The following is a description of a gene set: species: Homo sapiens Human Gene Set: REACTOME_CYCLIN_A_CDK2_ASSOCIATED_EVENTS_AT_S_PHASE_ENTRY Cyclin A:Cdk2-associated events at S phase entry, and this is the list of marker genes: ADRM1, AKT3, PSMD11, CDKN1A, PSMD7, MAX, CDC25A, WEE1, CDK7, PSMB2, SKP1, LIN54, SEM1, TFDP1, PSMB1, CUL1, E2F4, UBA52, CCNE1, UBC, PSMB7, CCNA2, CCNE2, PSMC2, CDKN1B, MYC, PSMC4, PSMC1, LIN52, PSMB6 (proteasome 20S subunit beta 6), CDK2, E2F5, CABLES1, PSMB4, TFDP2, PSMD8, PSMB5, PSMA6, PTK6, PSMD6, PSMB3, LIN37, CKS1B, RBL2, FZR1, CCND1, LIN9, PSMD14, PSMA7, UBB (NCBI Gene Id 91253), PSMC5, PSMD3 (proteasome 26S subunit, non-ATPase 3), PSMC6, CDK4, PSMA1, CDC25B, CCNH, PSMA3, AKT2, CCNA1, PSMA2, RB1, RBBP4, AKT1, PSMD2, E2F1, PSMD12, PSMC3, PSMA5, PSMA4, SKP2, RPS27A, MNAT1, PSMD13, PSMD1